The following is a description of a gene set: Human Gene Set: HE_LIM_SUN_FETAL_LUNG_C3_DEFINITIVE_RETICULOCYTE Definitive reticulocyte from publication He P, Lim K, Sun D, Pett JP, Jeng Q, Polanski K, Dong Z, Bolt L, Richardson L, Mamanova L, Dabrowska M, Wilbrey-Clark A, Madissoon E, Tuong ZK, Dann E, Suo C, Goh I, Yoshida M, Nikolić MZ, Janes SM, He X, Barker RA, Teichmann SA, Marioni JC, Meyer KB, Rawlins EL (PMID 36493756) species: Homo sapiens, and this is the list of marker genes: SLC22A4, HBQ1, ATG14, NPL, SPTA1, SLC6A9, RAP1GAP, RIPOR3, SMIM1 (small integral membrane protein 1 (Vel blood group)), HBZ, PIM2, PPME1, CR1L, DYRK3, KRT1, DNAJC6, RGS6, IBA57, SLC14A1, ESPN, HBB, STK17B, SOX6, CPEB4 (NCBI Gene Id 80315), SPTB, CMPK2, FAXDC2, RHD, XPO7, NCEH1, FHDC1, MOSPD1, PRR5, YPEL4, RFESD, LPIN2, ARG1, MYL4, CPOX, TFR2, XK, TRAK2, C17orf99, TUBB1, NFE2, TMCC2, UBE2O, TBCEL, ERMAP, SIAH2 (siah E3 ubiquitin protein ligase 2), HMBS, TLCD4, SDE2, SPECC1, GFI1B, NATD1, FBXO30, KIAA0232, TENT5C, HBM, TCP11L2, GYPB, ATG4D, OSBP2, ANKRD9, RHAG, SMOX, KLF1, TESC, ACSL6, KEL, GYPA, TMEM86B, SLC4A1, YOD1, CHST2, MRC2, CHST11, MOB1B, TRIM58, TANGO2 (transport and golgi organization 2 homolog), RUNDC3A, GMPR, GCLC, ELL2, ART4, AHSP, EPB42, TSPAN32, RSAD2, CA8, ALAS2 (NCBI Gene Id 90735), ANK1, GYPE, HEMGN, TRIM10, PHOSPHO1, PLEK2, E2F2, TSPO2, HECTD4, MFSD2B, SLC1A5, GATA1, UBAC1, SERPINI1, TFRC, SMIM5, SLC7A5, RHCE, DCUN1D1